The following is a description of a gene set: studied in species Homo sapiens Radial deviation of finger Human Gene Set: HP_RADIAL_DEVIATION_OF_FINGER Bending or curvature of a finger toward the radial side (i.e., towards the thumb). The deviation is at the metacarpal-phalangeal joint, and this finding is distinct from clinodactyly., and this is the list of marker genes: NPAP1, WNK3, CNOT1, ALX3, BBS1, ARL6, BCOR, FGFR3, GDF5, CHSY1, CPLANE1, SNORD115-1, SMAD4, OFD1, FGFR2, TRPV4, CCDC28B (NCBI Gene Id 79140), IGF1R, CANT1, SNORD116-1, PTPN11, TGDS, PHGDH, PWAR1 (NCBI Gene Id 8122), MAP2K1, EZH2, MKS1, WNT5A (NCBI Gene Id 7474), ESCO2, CILK1, SIN3A, SF3B4 (splicing factor 3b subunit 4), MEGF8, PWRN1, FGD1, BMPR1B, FLNA, ROR2, CRLF1, DVL1, NOG, MAGEL2, HERC2, BPNT2, BRAF, SLC26A2, ALG9, MKRN3, NAA10, CD96, IHH, PIK3R1, ATRX (ATRX chromatin remodeler), IFT122, FLNB, TRAF7, MED12, ANKRD11, BMP2